The following is a description of a gene set: Genes up-regulated in CD8A dendritic cells with IFNAR1 knockout: control versus primary acute viral infection. Murine Cytomegalovirus (MCMV) infection leads to early activation of various immune cells, including B and T lymphocytes, before the actual initiation of antigen-specific adaptive immunity. This activation is partly driven by innate cytokines, including type I interferon (IFN), which are induced early after infection. The objective of this study was to address the role of type I IFN in shaping early/innate B and T cell responses to a primary acute viral infection. In order to decipher the specific impact of IFN-I on cell subsets, we performed a genome-wide expression analysis on WT splenic B and CD8 T lymphocytes isolated from C57BL/6 mixed bone marrow chimera mice. This study complements series GSE39555, which focused on early responses of NK cells and of the two subsets of conventional dendritic cells. studied in species Homo sapiens Human Gene Set: GSE45365_HEALTHY_VS_MCMV_INFECTION_CD8A_DC_IFNAR_KO_UP, and this is the list of marker genes: TRIAP1, CD46, STX6, RASGRP2, PDE3B, MRPL48, EIF3E, CCNG1, SH2D3C, HHLA1 (NCBI Gene Id 10086), PAM16, PSEN2, PSG6, INPPL1, CTBP1, IL13RA1, IMPACT, TDRD1, UCK2, TNIK, OCA2, HAX1, CIITA (class II major histocompatibility complex transactivator), SLC25A6, PCYOX1L, MRPL34, TRAPPC9, SARAF, ACVR2B, STX8, RPA3, SGSM2, TTC31 (NCBI Gene Id 64427), DMWD, ATP2B4, ACAD8, ZNF862, VPS52, ZDHHC4, SLC35E2B, KDM1A, ACTR1B, MANBA, SLC5A1, TAF7L, TCEA2, CLCN7, FOXE3, TCP11L1, EOLA2, ATP5F1B (NCBI Gene Id 506), PMS2P11, SFTPC, EOLA1, SNU13, CST8, ZFTA, IMPDH2, PRIM1, TMSB10, C4orf19, RPL10, KCTD13, PCCB, CDC42SE1, MBOAT2, SCNN1G, RPSA, GRPR, ACAA2, CAT, KCNAB1, ATIC, LYST, PGAP2, RABEP2, RPL9, KYAT3, TRAPPC12, GRK6, SERP1, OSTF1, RPS27L, RPS8, GPR153, PNPLA4, ANP32A, FASTK, TXNDC15, NCAPH, PLSCR3, PABPC3, SCNM1, GGA2, SPDL1, AXIN1, PARN, MCCC2, SLC5A6, P4HTM, PIGG, GPRC5D, CHODL, SNHG32, BRD3, CRIP1, TOGARAM1, NOP53, PAAF1, CLNS1A, EPRS1, USP21, TRAFD1, RPL11, KDELR3, IL17RC, MICAL1, ENOX1, RRAS, G6PC3, NRGN, DNAJA3, EXTL2, MAP3K1, UROS, RIDA, GYPC, LALBA, IFFO1, ZNF197, THYN1 (NCBI Gene Id 29087), RPL23, ACTG1, SIRT3, LAMP3, MAPK14, LYPLA2, TBC1D8, NDRG2 (NDRG family member 2), INVS, MRPS33, OSBPL9 (NCBI Gene Id 79638), ZDHHC24, RIOX1, PDHA1, ATXN7, ARPC1B, PRORP, SPAG7, ACY1, OXA1L, SYNGR2, FOXO1, LANCL1, TMEM39B, GRK2, RSAD1, TMED3, SPECC1L, DHRS3, VWF, SCPEP1, JUND, RPS6KA1 (NCBI Gene Id 6195), RPL37, AHCTF1, POLR2I, MCM3, MRPS18A, KNTC1, CAMK2B, MMP24, TXN2, NUCKS1, NSD2, MAP2K2, SPON2, SHQ1, BLM, EIF3L (eukaryotic translation initiation factor 3 subunit L), IER5, PPOX, HAUS4, NKRF, NAA40, MNT, LTF, CDKL1, WDR77, B3GALT4, REPIN1, CCDC28B, ICMT, COLEC12, MAPK9, SCAMP3, SAYSD1